Given this list of marker genes ADSL, ATIC, PAICS, PPAT, ADSS2, PFAS, ADSS1, GART, here is a description of the gene set: species: Homo sapiens Human Gene Set: GOBP_DE_NOVO_AMP_BIOSYNTHETIC_PROCESS The chemical reactions and pathways resulting in the formation of adenosine monophosphate (AMP) from inosine 5'-monophosphate (IMP).